Given this list of marker genes OTUD1, CDC42EP2, KCTD20, ANXA5, SIGLEC9, DNTTIP2, LILRB2, GPR137B, ANGPTL4, CD55, DENND5A, MAD2L2, NOTCH2, TMEM120A (transmembrane protein 120A), TNFSF8 (TNF superfamily member 8), RP2, RAB7A, ASPH, DOCK10, DAZAP2 (DAZ associated protein 2), EPB41L3, GNA15, RASSF4, NCOR2, C1orf122, CXCL2 (C-X-C motif chemokine ligand 2), EML4 (NCBI Gene Id 54548), CYTOR, UBR4, CXCL1, ERGIC1, IRAK2, GPR132, CD58, PARP14, PHC2, TOP1, IL4I1, ATP2B1-AS1, IRAK3, UBE2E1, FURIN, SEC61G, CHST15, RNF145, ATP5MK, HMOX1, DDX60L, IL1RN, RAB1A, CLIC4, DPH3, MIR3945HG, PCBP1, PLEKHG2, MYD88, LITAF, CLDN5, H3-3B, BRI3, FCGRT, B4GALT5, NBPF10, SPAG9, PTAFR, FOSB, RARA, FCGR1A, RANBP2, GLIPR2, SERP1, CLEC7A, KPNA4, MAP2K3, HCAR2, CLEC4A, IL1B, ITPRIPL2, SRGN, CHMP4B, DDX3X, PNPLA8, IL6, NCF2, ERCC1, ADAM19 (NCBI Gene Id 8728), HCK, EIF4G2, ACSL5, ZFP36L1, ACTB, RPS9, LST1, TFRC, FCAR, RIPK2, GK5, CCL20, SERPINB1, ATP6V1F, FCER1G, PPP1R3B, MAT2A, CFP, VEGFA, ERBIN, EMP3 (epithelial membrane protein 3 (MAM blood group)), CCL2, TMEM165, PDE4A, HIP1, EPAS1, KDELR2, ZNF385A, FLNA, MARCKS, RAB20, SNHG15, TRMT6, PURB, PKM, DRAM1, S100A9, CLTC, DMXL2, PTPN1, EMP1, KLHL5, GPX4, SLC11A1, C5AR1, ECE1, DUSP6, KYNU, SQLE, MPHOSPH6, BATF3, GBP1 (guanylate binding protein 1), CEP170, CARD19, FAM107B, FCGR2A, EAF1 (ELL associated factor 1), STX11, AZIN1, FNDC3A, PPP1CB, GNA13, CSNK1A1 (casein kinase 1 alpha 1), ELL, AZI2, RGS10, ZEB2, GPR183, OLR1, PDE4B, CTNNB1, C9orf72, UAP1, GPR35, DYSF, PTPN2, SH2B3, PMEPA1, ITGA5, STK40, PLEKHB2, TRAPPC5, MIR4435-2HG, LILRA1, MAFB, EREG, GSTO1, LRG1, NPC2, GBP2, MCL1, ATP6V1C1, COX8A, NFKBIE, ITGAV, HIPK3, SKI, SLAMF1, DOT1L (NCBI Gene Id 84444), IL6ST, ASAP1, SERF2, GNB4, CHMP1B, HNRNPA2B1, BID, CD300E, TNS3, LYZ (NCBI Gene Id 4069), TRIM25, ATP1A1, GK, MAP2K1, WDFY3, HIVEP2, BACH1, TCIRG1, KRAS, SOD2, ELL2 (elongation factor for RNA polymerase II 2), MT2A, VDR, METRNL, IL6R, ZC3H12A, ICAM1, CYBB (NCBI Gene Id 1536), RBM47, MYH9, HNRNPA3, RELB, LILRB3, ADAM9, ACTN1, RALA, PLEC, BCL3, PIK3AP1, MX2, PDXK, LACC1, VCAN, ATP6V1B2, ADAM8, PFKFB3, LILRA6, OGFR, RPS26, SLC2A3, SLC6A6, ADA, RBP7, FLOT1, KANK1, FOS, JARID2, PPIF, NUS1, HPSE, GNA12, CIMAP1B, PLSCR1 (phospholipid scramblase 1), ATP5MJ, SUSD6, CD93, SLC7A5, PDSS1, QPCT, IL1R1, RAB8B, SNHG16, HCAR3, SIGLEC14, BCKDK, H3P6, CD44, RAB13, PPP1R15B, CAPNS1, PIK3R5, NAMPT, MS4A7, WDR1, SPPL2A, BZW1, SLC16A10, ACTR3, ATP2A2, CCL3, LIMS1, CYSTM1, IFI30, LUCAT1, SEC61B, RN7SL1, CXCL8, SLC43A2, DSE, VPS9D1, NFAT5, AQP9, DPYD, CD163, SMPDL3A, IVNS1ABP, APOBEC3A, CTSH, SEMA6B, PTPN12, TNFAIP8, DDX3Y, NDST2, RTN4, RUNX1, FNDC3B, CAMKK2, FOSL2, EMILIN2 (NCBI Gene Id 84034), ARFGAP3, MCUB, SLCO4A1, PEDS1, ACTG1, THBD, SLC1A3, GNB1 (G protein subunit beta 1), RAC1 (NCBI Gene Id 5879), SMS, CD274, GABARAP, LYN, MAP3K7CL, MAP3K20 (NCBI Gene Id 51784), ANTXR2, GPCPD1, HIVEP3, ATP1B3, HIF1A, TPP1, PLIN3, PELATON, NIBAN2, UFM1, SIRPA, SQOR, PNP, JAK1, IL1R2, IFNAR1, SIPA1L1, PSMA6, ENO1, ZNF267, C3AR1, BIRC2, ACSL1, ZDHHC20, ARF6, KCTD12, BASP1, STEAP4, CSF2RA, ZBTB43, RHOA, ARL8B, ANPEP (alanyl aminopeptidase, membrane), SDC2 (syndecan 2), GPX1, EPSTI1, MIR22HG, UBE2D1, WARS1, SLC25A37, METTL9, TNFAIP6, APLP2, XBP1, ISG15, SH3GLB1, LILRB1 (leukocyte immunoglobulin like receptor B1), PDLIM7 (NCBI Gene Id 9260), AK4, PICALM, LMNB1, SAT1 (spermidine/spermine N1-acetyltransferase 1), FTH1, SNX9, DNAJB6, ZNF706 (zinc finger protein 706), CFLAR, SKIL, CKAP4, NUMB, NFKB1, ATP5F1E, STX6, TMED5, SH3BP2, SDCBP, SNX10, ARF4, PET100, TPM4 (NCBI Gene Id 7171), SPI1, HAMP, HNRNPM, RABGEF1, SNAI1, ETV6, CYFIP1, LILRA5, SMCO4, MMP19, ZNFX1, HAVCR2, EIF4G1, CXCL3, PPP1R18, N4BP1 (NEDD4 binding protein 1), CLEC5A, IGSF6, DUSP1, C4orf3, ATP2B1, HMGA1, SLC36A4, OLIG1, FKBP5, RAPGEF2, RIN2, TIMM17A, IL10, UPP1, SUB1, PITPNA, ARHGAP31, ETF1 (eukaryotic translation termination factor 1), TLNRD1, CASP4, ENG, ARHGDIA, USP32, TET2, CEBPB, RGCC (NCBI Gene Id 730127), EMD, SERPINB9, NBPF14, SAT2, AGO2, DNAAF1, SLC66A2, CTSS, OSM, S100A12 (NCBI Gene Id 6283), RAB10, TNFAIP2, G0S2, S100A10, GSAP, IFNGR2, EHD1 (EH domain containing 1), WTAP, POMP, MCEMP1, TYMP, GNG5, IL1RAP, TRIP12, ARPC5, PXN, CTNNA1, ACSL4, IRS2, EIF1B, TNIP3, RBM17, MXD1, SLC16A6, MAPRE1, PRELID1, STK24, RALGDS, TYROBP, LY96, RNF19B, ARRB2, SLC43A3, IFIT3 (NCBI Gene Id 8376), AHR, ACTR2, GABARAPL1, NBN, EIF1, CSRNP1, TRAF1, FPR1, CTSL (cathepsin L), CLIC1, PLEKHO2, EHBP1L1, CCNL1 (NCBI Gene Id 57018), RAPGEF1, BCL2A1, CDKN1A (NCBI Gene Id 1026), HCLS1, NABP1, TGFBI, YWHAZ, PIM3, NDUFV2, ARL4A, IL4R, ABCA1, ACOD1, SRC, PRNP, ADAM17, TPT1, RGL1, HSPA5, PHLDA2, GAPDH, LIMK2, ELK3, S100A11, NFKBIA, PTX3, LGALS1, RBMS1, LAT2, ROCK1, YWHAE, NLRP3, PEA15, NEAT1, LILRB4, MAP3K8, SOCS3, MTF1, CDV3, EIF4E, UBE2D3, TREM1, IRF2BP2, BCAT1, SFPQ, RILPL2, TCN2, CD53, HNRNPC, FMN1, INSIG1, HSBP1, ATF3, MAP1LC3B, TPST1, ADA2, QKI, ZSWIM6, TMEM167A, TNFRSF1B, SLC16A3, NECTIN2, LHFPL2, CD83 (NCBI Gene Id 9308), MPP1, TIMP1, VASP, TLE3, ADGRE2, HBEGF, GCH1, CCR1, LCP2, SLC15A3, SLC44A1, FPR2, YWHAG, LDHA, PTGER2, CUX1, ELOC, TOM1, MARCKSL1, CD14, STARD4, CYRIA, AIF1, IFITM3, SERPINB8, MTCH1, TNFRSF1A, AMPD3, NOP10, PPP1R15A, CSF3R, PCNX1, NDRG1, YBX3, MTSS1, HIPK2, ETS2, MAPKAPK2, ST3GAL2, ZYX, TNIP2, B3GNT5, ATF5 (activating transcription factor 5), FNIP2, FGR, CHIC2, CHST11, KLF10, DICER1, ADM, IL13RA1, PSEN1, SAR1A, CLEC4D, SERPINA1, GADD45B, CTSB, SLA, IRF7, ABL2, FTH1P3, LACTB, MED13, RRAGC, NINJ1, SLC2A6, DGAT2, CFD (complement factor D), PSAP, VIM, UBL5, TP53BP2, CXCL10, CHD1, SMIM3, SAMSN1, S100A8, ALOX5AP, ITGAX, ZMIZ1, FLT1, C15orf48, TNFAIP3, EFHD2, SPCS3, NUP62, LAP3, FFAR2, FERMT3, MSN, MYO1G, MYL6, IQGAP1, KDM7A, GPR84, PTGS2 (prostaglandin-endoperoxide synthase 2), RPS24, SNN, PELI1, MAP4K4, GCA, MKKS, KCNN4, ATF6 (activating transcription factor 6), TNIP1, FCN1, TLR2, S100A6, LCP1, SHOC2, PLK3, DOK3, SURF4, RNF144B, SLC39A8, THBS1, PLEK, SYK, IRAK1, LAIR1, STXBP2 (NCBI Gene Id 6813), IPO7, NEK6, PID1, CLEC4E, CASP1, CCL7, SBNO2, PGK1, CCRL2, ATP13A3, SIGLEC10, BAZ1A, LRRC8C, ACSL3, CPD, CSTA, UBE2Z, SCO2, HS3ST3B1, EHD4, ARPC1A, CXCL16, MIDN (NCBI Gene Id 94034), GRINA, PFN1, RYBP, SPHK1, PNRC1, FPGS, PSTPIP2, GRB2, CMTM6, GRAMD1A, STAT3, MAML2, CSTB (NCBI Gene Id 1476), MARCHF2, AGFG1, KDM6B, TLR4, IER3, RAB31, ANXA2, DDX21, PLAUR, IL1A, PPP4C, N4BP2, P2RX4, CPVL, NRIP3, here is a description of the gene set: Human Gene Set: TRAVAGLINI_LUNG_OLR1_CLASSICAL_MONOCYTE_CELL from publication Travaglini KJ, Nabhan AN, Penland L, Sinha R, Gillich A, Sit RV, Chang S, Conley SD, Mori Y, Seita J, Berry GJ, Shrager JB, Metzger RJ, Kuo CS, Neff N, Weissman IL, Quake SR, Krasnow MA (PMID 33208946) studied in species Homo sapiens